Given this list of marker genes Imp4, Rnasel, Sbds, Rpl3, Tst, Rpl7, Rps11, Rps13, Gtf3a, Rpf1, Rpl9, Rpl17, Lipe, Mterf4, Ngrn, Rps4x, Mrps17, Rps3, Rps18, Npm1, Nop53, Mrpl20, Ddx28, Rplp0, Fastkd5, Mrps7, Rpl19, Rpl23, Mrps18c, Rpusd4, Rrs1, Mrps18a, Mdm2, Cirbp, Rpl12, Kdm2b, Utp23, Map3k20, Fastkd2, Rcc1l, Rpl6, Ppan, Hmgb1, Rpl23a, Utp25, Mrpl11 (mitochondrial ribosomal protein L11), Rps9, Brix1, Eral1, Mrps27, Snord87, Rpl4, Rpl8, Eri1, Imp3, Rpl37, Cavin1, Rpl11, Nsun4, Mrpl16, Ddx21, Mrps6, Mrpl18, Ncl, Tlr13, Nol12, Rpf2, Emg1, Eef2, Rpl5, Rps5, Ptcd3, Taco1, here is a description of the gene set: Binding to a ribosomal RNA. species: Mus musculus Mouse Gene Set: GOMF_RRNA_BINDING